The following is a description of a gene set: from publication Ventre E, Brinza L, Schicklin S, Mafille J, Coupet CA, Marçais A, Djebali S, Jubin V, Walzer T, Marvel J (PMID 22942430) Genes up-regulated in comparison of memory CD8 T cells treated with IL4 and IL7 versus naive CD8 T cells treated with IL4 and IL7. species: Homo sapiens Effects of IL-4 on CD8 T cells functions are largely unknown. IL-4 induces survival and proliferation of CD8 T cells, but several studies suggest that IL-4 could also affect several functions of CD8 T cells such as cytotoxicity. Our team has shown that IL-4 repress the expression of Ccl5 in vitro. To define more precisely the impact of IL-4 on CD8 T cells, we performed a whole genome expression microarray analysis of naive and memory CD8 T cells cultured in presence or absence of IL-4. This approach allowed us to define the IL4-gene-expression signature on CD8 T cells. Human Gene Set: GSE32423_MEMORY_VS_NAIVE_CD8_TCELL_IL7_IL4_UP, and this is the list of marker genes: SST, IL18RAP (interleukin 18 receptor accessory protein), RNF182, ZNF354B, C19orf33, CTDNEP1, SMTN, IFNA1 (interferon alpha 1), TNFSF13B, ABCB1, MTMR7, EFS, ITIH1, TSPAN31, OTOP2, MYO6 (myosin VI), IL15RA, NEU2, NPC2, FCER1G, HSD17B14, HS3ST4, FARP1, ASAH2, FXYD6, LARGE1 (NCBI Gene Id 9215), CAMK2A, MIA2, HOXB1 (NCBI Gene Id 3211), NR1D1, BANK1, BEX2, PRKG1, DCDC2, CPNE4, FABP2, GPX7 (glutathione peroxidase 7), PLAC8L1, ECHDC3, VSTM2B, PAK6, CRISPLD1, CASK, TRH, SYT6, OVOL2, CFHR1 (complement factor H related 1), C5AR1, LLCFC1, GATA6, CSF3R, ODF1, ZBTB42 (NCBI Gene Id 732257), SELE, COQ10A, PLPPR5, ALDH5A1, TAL1, MARCHF1, RPRM, REG3A, FBXO16, CA11, CD86, ART3, CNN1, MMRN1, NDUFV3, ZBP1, APOA1, P2RY2 (NCBI Gene Id 5029), ANGPT4, WDR64 (WD repeat domain 64), NEUROD6, PLEKHA8, ZSCAN12, PRSS12, NEFL (neurofilament light chain), NOTCH3, GLIS1, SUSD5, SLC22A17, DNAJC22, BDH2, TFAP2A, SLC52A3, FBXL18, SELENOW, OSBPL6, ADAT3, SCARA5 (NCBI Gene Id 286133), NAAA, KCNJ11, HOPX, RS1, MBOAT1, MYRFL, TENT5A, CNTN2, ZFAND2B, HEBP1, SPRR2A, HFE, SPATA25, LRRC19, CHIC1, FXYD1, LRMDA, OS9, CRYBG3, LRRC15, NPHS1, FCGR2A, ADAM33, SERPINB1, INPPL1, JPH4, GAPDHS, C1QTNF1, HK3, HOXC10, SERTAD4, NBAS, KCNE5, PSCA, IL24, DDB2, ST6GALNAC1, SLC36A2, COX6B2, GNG4, CTTNBP2, KRTAP8-1, PTGFR, MGAT4EP, GLRX, KCNC2, TFAP2B, MFSD10, C19orf81, TPTE, ZKSCAN4, TTLL6, ADRA1A, CTDSP1, NRARP, SLC34A2, ARHGEF40, FXYD4, FUT2, ARHGDIA, APBA1, CYP21A1P, PCBD1, SMPDL3B, SLC47A1, FAM229A (family with sequence similarity 229 member A), SYK, FAM135A, GRM5, PRRT3, ADARB1 (adenosine deaminase RNA specific B1), NUPR2, CAMK2N1, TMCO4, NRK, DHH, PRDM1, POMGNT2, SLC34A3 (solute carrier family 34 member 3), RNF216, SUSD3, DTX3, VIP, MXD3, CA6, IRS1, ENPP3, RBP7, CRYGS, RIMS3, ASCL2, RAD51B, NOD1, ADRB3, LRRC18, TBC1D5, SDCBP2 (syndecan binding protein 2), RNASE4, S100B, TEAD4, WARS2, CHRNA5, FZD6, SHFL, OSGIN1, CLIC1, LBX2